The following is a description of a gene set: from publication Chessler AD, Unnikrishnan M, Bei AK, Daily JP, Burleigh BA (PMID 19201883) Human Gene Set: GSE13522_CTRL_VS_T_CRUZI_Y_STRAIN_INF_SKIN_129_MOUSE_UP To investigate the early host response triggered by three different strains of Trypanosoma cruzi at a local infection site, changes in host gene expression were monitored in a murine intradermal infection model using Affymetrix oligonucleotide arrays. Robust induction of IFN-stimulated genes (ISGs) was observed in excised skin 24 hours post-infection where the level of ISG induction was parasite strain-dependent with the least virulent strain triggering a muted IFN response. Infection of mice immunodepleted of IFNγ-producing cells or infection of IFNγ-deficient mice had minimal impact on the IFN response generated in T. cruzi infected mice. In contrast, infection of mice lacking the type I IFN receptor demonstrated that type I IFNs are largely responsible for the IFN response generated at the site of infection. These data highlight type I IFNs as important components of the innate immune response to T. cruzi the site of inoculation and their role in shaping the early transcriptional response to this pathogen. We used microarrays to detail the local host transcriptional response to intradermal T. cruzi infection in WT mice and mice depleted of NK cells, or deficient in IFN-gamma or type I IFN responses. Additionally we compared the local host-transcriptional response generated to infection with 3 different strains of Trypanosoma cruzi (Y, Brazil, and G). Genes up-regulated in skin from 129S1 mice after injection of: control versus Trypanosoma cruzi (strain Y). studied in species Homo sapiens, and this is the list of marker genes: HPS6, AMZ1, RRS1, CRISPLD1, RASGRF1, KATNAL2, OC90, NBL1, ENTPD1, UBE2L3, CPLX2, NRN1L, PLIN5, KIF13A, SPECC1, NAF1, PARD6G, CRP, GPR143, PSMB11, NDUFS5, MED11, IZUMO1, PRR15L, FBXO10, MIRLET7B, KIF5C, RAPSN, S100A11, PGLYRP4, ESAM, PHEX, NIPSNAP3A (nipsnap homolog 3A), TNNI2, POMGNT2 (NCBI Gene Id 84892), LY6G6C, XCR1, MSRB2, PCLO, NPW, MEP1B, COL15A1, PANX3, TMEM45B, KRT39, ZFP28, WFDC5, EZHIP, UBQLN1, DPPA4, RARRES1, ASPG, RDH8, BIRC7, FAM170B, IGFN1, HHEX, ITPKA, NEB (nebulin), PLCD3, COL9A1, F2RL2, CBLIF, SULT1D1P, NECTIN4, TM4SF20, ALDH5A1, MIR491, PKHD1, KCNMB4, REPS1, ADORA2B, SCARA3, GRIN2C, FAM24A, SEMA6A, FOXI3 (NCBI Gene Id 730270), IL23R, CASTOR2, HNMT, MIR200B, ZAN, FBXL22, CAPN1, LRRC63, TAAR9, MDGA1, PLA2G4F, MIR194-2, FAM222B, FOXJ2 (forkhead box J2), GNA15, BMP8B, SOHLH1, INPP5J, AIDA (NCBI Gene Id 92615), SRY, POU2F3, ABCA2, KIF26B, RBP7 (NCBI Gene Id 116362), MORN3, SDC4, GNPTG, ERN2, ABCA4, SND1, CLEC10A, ZSCAN29, MTARC1, ZER1, CD40, NR6A1, PLA2G1B, S100A16, FAM43A, MYL9, ZDHHC1, RBM20, SRC, EPHA10, GPR82, FASN, CNTN1, SYT5, NRP1, CTU1, RPRD1B, CLEC4G, KCNK7, ZP3, RSPH14, ABRA, PNPLA1, ARRDC4